The following is a description of a gene set: Catalysis of an oxidation-reduction (redox) reaction in which a CH-NH group acts as a hydrogen or electron donor and reduces a hydrogen or electron acceptor. species: Mus musculus Mouse Gene Set: GOMF_OXIDOREDUCTASE_ACTIVITY_ACTING_ON_THE_CH_NH_GROUP_OF_DONORS, and this is the list of marker genes: Blvrb, Aldh1l2, Qdpr, Aifm1, Noxred1, Paox, Pycr2, Prodh2 (NCBI Gene Id 80566), Mthfd2, Mthfd2l, Sardh, Aass, Dhfr, Mthfr, Dmgdh, Crym, Prodh, Aldh1l1, Etfdh, Mthfd1l, Pycr1, Smox, Pycr3, Mthfd1, Aifm2, Pipox